Given this list of marker genes AMOT, WDTC1, FBRSL1, GPX1, F13A1, COX14, TFAP2D, SMG7, AKIP1, FAM120A, PCDH15, MTF1, BTAF1 (NCBI Gene Id 9044), CC2D1B, KDM6B, ELFN2, COMMD3-BMI1, TMEM170B, ZNF773, PLEKHO1, JARID2, FMNL3, MAPT, C11orf71, SLK, SLC26A5, BTF3L4, RHO, C6orf62, PCSK7, SPATA33, PRSS55, BHMT2, DSG4, PAX5, KCNQ2, KRBOX5, GRID1, APH1A, TSPAN9, MEIOC, BMI1, PRUNE1, NSF, NFASC, here is a description of the gene set: studied in species Homo sapiens Human Gene Set: MIR6865_3P from publication Chen Y, Wang X (PMID 31504780) Genes predicted to be targets of miRBase v22 microRNA hsa-miR-6865-3p in miRDB v6.0 with MirTarget v4 prediction scores > 80 (high confidence targets).